Given this list of marker genes Lcat, Apoa4, Apoa5, Apoa2, Apoa1, Apoe, here is a description of the gene set: Catalysis of the reaction: phosphatidylcholine + a sterol = a sterol ester + 1-acylglycerophosphocholine. studied in species Mus musculus Mouse Gene Set: GOMF_PHOSPHATIDYLCHOLINE_STEROL_O_ACYLTRANSFERASE_ACTIVITY